The following is a description of a gene set: A cell junction that forms a connection between two or more cells of an organism; excludes direct cytoplasmic intercellular bridges, such as ring canals in insects. Mouse Gene Set: GOCC_CELL_CELL_JUNCTION studied in species Mus musculus, and this is the list of marker genes: Aqp7, Cldn9, Akap6, Ptk7, Ssx2ip, Wdr1, Abcb1a, Dsg1b, Ptpn6, Fxyd1, Des, Def6, Sorbs1, Tjp1, Grb2, Nectin3, Cdhr18, Nck1, Opalin, Gja6, Panx1, Atp1a2, Dsg1a, Cldn5, Ptprm, Lin7b, Ppl, Pikfyve, Cntnap2, Fscn1, Tmem65, Iqgap1, Coro1a, Cldn34c2, Sptbn2, Itk, Snap23, Rasip1, Tek, Dlg3, Stard10, Myh2, Dsg1c, Cxcr4, Epb41l3 (NCBI Gene Id 56528), Cldn11, Fat2, Lcp2 (lymphocyte cytosolic protein 2), Vamp5, Kcnj2, Anxa5, Rdx, Cldn13, Adam17, Mylk, Ccdc85c, Cdh19, Strn, Pdlim2, Fndc1, Ybx3, Gjd3, Arhgef2, Kirrel1, Cdh9, Cyth1, Abi2, Sapcd2, Pik3r1, Slc5a1, Pip5k1c, Ddx6, Pkp2, Ldb3, Ajap1, Frmd4a, Cdc42ep4, Cdca3, Krit1, Carmil2, Gm1123, Mtdh, Cdh5, Rnd1, Rab13, Cldn34b2, Nectin2 (NCBI Gene Id 19294), Dlg4, Zap70, Igsf5, Ctnnal1, Ceacam2, Aoc1, Grhl2, Flrt2 (fibronectin leucine rich transmembrane protein 2), Ank3, Hepacam, Dbn1, Actn1, Cldn22, Akr1b1, Pkp3, Atp7b, Marveld3, Crb1, Ocln, Ubn1, Cdsn, Nphp4, Cdh17, Wnk3, Scn1a, Cadm4, Csk, Itgb3, Dsc3, Prkcd, Asb17, Lim2 (NCBI Gene Id 233187), Samt3, Pacsin2, Obscn, App, Mpp1 (membrane protein, palmitoylated), Frmpd2, Micall1, Niban2, Jcad, Flrt3, Atp2a2, Shroom1, Ehd4, Nectin4, Cldn25, Cdh13, Tiam1, Ank2, Mpp3, Mmp13, Cldn34a, Clic4, Gjb4, Ctnnd1, Itgb1 (integrin beta 1 (fibronectin receptor beta)), Pdcd6ip, Frmd5, Rap1b, Tchp, Tjp2, Ndrg1, Eppk1, Epha2, Lsr, Fzd5, Cldn1, Prkca, Slc9a1, Cldn34c6, Skp1, Shroom2, B4galt1, Themis (NCBI Gene Id 210757), Plcg1, Arvcf, Frmd6, Ect2, Pdxp, Lims2, Pvr, Myh1, Pard3, Cldn34d, Ctnna2, Podxl, Col13a1, Iqgap3, Tnk2, Tgm1, Jam2, Gjb1, Vinac1, Prkch, Cdh1, Add1, Synpo, Synm, Plekha7, Kit, Cldn4, Fzd4, Ngfr, Uba1, Cdh3 (cadherin 3), Cldn10, Limd1, Esam, Pdlim7, Marveld2, Tspan33, Micall2, Dst, Kcnj11, Cav3, Prkcz, Hamp, Ppp1ca, Yap1, Skap1, Igsf11, Cldn7, Gm14569, Itgal, Flot1, Dchs2, Sgsm3 (small G protein signaling modulator 3), Abcb4, Mpp4, Clmp, Ajm1, Gjc1, Mpdz, Cldn34c1, Smad7, Sgca, Jam3, Mpp7, Samt2b, Plekhg5, Ceacam1, Cdh18, Cd2ap, Dsg3 (desmoglein 3), Mtss1, Adam10, Pcdhgc3, Lyn, Cd3e, Amot, Ilk, Prkci, Cask, Cadm1, Cldn12 (NCBI Gene Id 64945), Pxn, Ahnak, Keap1, Usp53, Perp, Nphs2 (NCBI Gene Id 98428), Ptpru, Pnn, Ctnna3 (catenin alpha 3), Epcam (epithelial cell adhesion molecule), Kcna2, Cadm3, Pdlim4, Gjb3, Rapgef2, Pcdh9, Nphs1 (nephrosis 1, nephrin), Cdc42bpa, Mpp2, Cldn8, Ildr2, Pcdhga12, Heg1, Fabp7, Vapa, Trpc6, Wtip, Msn (moesin), Lck, Baiap2l2, Nfasc (NCBI Gene Id 269116), Myadm, Kirrel3, Cldn2, Efnb2, Tjap1, Cdh11, Ncam1, Sirt2, Nf2, Cldn34b4, Cldn17, Mapk15, Cdh10, Cdh2, Itga5, Gja8, Myh9, Arhgap24, Pdlim3, Pkp1, Rigi, Tbcd, Evpl, Slc2a2, Sptan1, Itga4, Ptk2, Trpc4, Amtn, P2rx7, Nrxn1, Ccdc85a, Hamp2, Cldn34c3 (NCBI Gene Id 382265), Cd99l2, Ocel1, Pard3b, Sptbn4, Xirp2, Cdh6, Sympk, Cfl1, Slc4a1, Ccdc85b, Klhl24, Camk2d (calcium/calmodulin-dependent protein kinase II, delta), Flot2, Cldn18, Twf1, Cldn15, Nphp1, Pcdh1, Dsc1, Adcyap1r1, Pof1b, Apc, Cldn16, Sh3kbp1, Samt1d, Cdc42, Gja4, Dsg4, Flrt1, Ash1l, F11r, Cdh20, Gab1, Patj, Ankrd23, Ywhah, Cntnap1, Ctnna1, Add3, Frmd4b, Pak1, Nherf4, Pcdha9, Cldn34b3, Abcb1b, Gjb6, Fgfrl1, Map2k2 (mitogen-activated protein kinase kinase 2), Actb, Fgf13, Wnk4, Anxa6, Ildr1, Cd2, Ctnnd2, Cdh4, Lin7a, Fgfr4, Sdccag8, Was, Amotl2, Rho, Scn1b, Lims1, Plxdc1, Cdh26, Tln2, Dsp, Ptprk, Lama1, Samt2, Cldn34b1, Trpv4, Slc2a1, Ctnnb1, Bloc1s6, Bves, Poldip2, Cldn20, Atp1b1, Samt1b, Hpn (NCBI Gene Id 15451), Aqp4 (aquaporin 4), Nectin1, Cldn14, Pcdhb12, Cgnl1 (cingulin-like 1), Vsig10l2, Dnmbp, Pals1, Prkd1, Rap2c, Dlg5, Rpgrip1l, Rhoa, Tmigd1, Pdzd11, Adam15, Ptprj, Vangl2, Calb2, Kifc3, Gria1, Magi1, Tec, Fermt2, Myo1e, Tmem47, Frs2, Lmo7, Dpp4, Gjb5, Pgm5, Rap2b, Pcdh12, Tgfbr1, Cdc42bpb, Specc1l, Fer, Epha4, Panx3, Cdh7, Kcna5 (NCBI Gene Id 213586), Akt1, Actr3, Traf4, Gja10, Luzp1, Ppp3ca, Ajuba (ajuba LIM protein), Magi2, Amotl1, Epb41l5, Dll1, Pkp4, Dag1, Itga6, Crb3, Pak2, Pals2, Cldn6, Nrap, Pdlim1 (NCBI Gene Id 54132), Camsap3, Flna, Rangrf, Cldn3, Stx2, Afdn, Stx3, Ahi1, Cldn23, Cdh24, Mxra8, Arhgef6, Crb2, Fbf1, Shroom3, Src, Tln1, Cd53, Capza1, Wasf2, Gjc3, Pkd2, Prickle4, Zyx, Tmem204, Dsc2, Scn5a, Ccnd1, Epha5, Cxadr, Cdh22, Pik3ca, Mlc1, Tenm2, Magi3, Gjd4, Alox8, Actg1, Pard6g, Xirp1, C1qtnf5, Shroom4, Dsg2, Kirrel2 (kirre like nephrin family adhesion molecule 2), Adgrl3, Pmp22, Sh3bp1, Pdzd2, Aqp3, Sdcbp, Abcb11, Vezt, Scn4b, Cdh15 (cadherin 15), Ccn3, Cyth2 (cytohesin 2), Ppp1r9b, Gjc2, Notch1, Cgn, Vcl, Wwtr1, Scrib, Ccdc88c, Gje1, Efna5, Pard6b, Pard6a, Pecam1, Krt8, Lrrc7, Pdlim5, Oxtr (NCBI Gene Id 18430), Fat1, Scn2a, Nexn, Tnks1bp1, Gja1, Gja3, Gjb2, Jup, Flcn (NCBI Gene Id 216805), Cdk4, Kazn, Sv2a, Epb41l4b, Slc8a1, Gjd2, Fhod1, Igsf21, Cldn24, Gja5, Lama3, Cdh12, Adra1b, Vegfa, Prkcg, Sipa1l3, Jaml, Lin7c, Cldn34c5, Pkn2, Bmpr2, Map3k1, Cldn19, Cdh8, Dlg1 (NCBI Gene Id 320792), Ezr, Fmn1, Gsn, Vasp, Vav1, Prkcz2, Actn4, Cldn34c4, Samt4, Slc31a1, Lat, Jag1, Abcc2, Arhgap17, Hmcn1, Atp1a1, Cyth3, Tjp3